The following is a description of a gene set: studied in species Homo sapiens Human Gene Set: REACTOME_ESTABLISHMENT_OF_SISTER_CHROMATID_COHESION Establishment of Sister Chromatid Cohesion, and this is the list of marker genes: ESCO1, SMC1A, PDS5B, CDCA5, RAD21, STAG1, WAPL, STAG2, PDS5A, ESCO2, SMC3